Given this list of marker genes Calm1, Spata6, Spata33, Slc22a14, Rho, Daam1, Cfap69, Dnah5, Hydin, Pkd2 (polycystin 2, transient receptor potential cation channel), Timd2, Slc26a6, Oaz3, Timd5, Dnai4, Acta2, Qrich2 (NCBI Gene Id 217341), Ccdc42, Cd24a, Omp, Crocc, Mlf1, Il4i1, Catsper2, Camsap3, Cimap1b, Ccdc65, Tmem262, Dnah17, Saxo4, Aldoart1, Cfap107, Klc3, Pierce2, Dnajb13, Tekt2, Bbof1, Marcks, Spaca5, Ift81, Ttll8, Tuba1a, Cimip4, Cfap90, Rap1a, Oxct2b, Dnah1, Cfap73, Dnai1, Spag4, Tsga10, Dydc1, Cabcoco1, Prkaca, Ace, Pkd1, Brwd1, Lyzl6, Cfap36, Scnn1a, Odf1, Catsperg2, Atp1a1, Iqca1, Lrrc46, Atp1a4, Slco6c1, Dnah7c, Mroh2b, Efcab6, Ssxb10, Sord, Catsperd, Septin4, Cfap210, Cfap70, Flacc1, Dnah7a, Kif9, Gli2, Fhad1, Ran, Drc7, Cimip2c, Cimip2b, Ssxb16, Pacrg, Akap4, Rnf38, Ift27, Slirp, Pmfbp1, Irgc, Efhc1, Saxo1, Dnah8, Pde1a, Spmip4, Tubb4b, Rsph6a, Tpgs1, Tacr1, Dnah7b, Nme5, Bbs2, Hif1a, Tssk1, Spag16, Cul3, Cfap276, Ssxb5, Rsph4a, Cimip2a, Ssxb3, Cfap43, Tssk6, Efcab9, Kcnu1, Gapdhs, Mns1, Dnai2, Pgk2, Dnah9, Rsph1, Ropn1, Atp1b3, Wbp2nl, Ccdc34, Cabs1, Fscb, Bbs1, Septin10, Ak2, Catspere1, Gstm5, Ccdc172, Atg16l1, Catsper3, Ssxb15, Drc3, Garin2, Dnhd1, Odf4, Ak7, Nherf1, Aldoa, Pierce1, Dnaaf11, Ribc2, Ropn1l, Cfap206, Tacr2, Anxa1, Dnah14 (NCBI Gene Id 381311), Ssxb14, Ift88, Slc9c1, Ssxb8, Ssxb13, Saxo2, Fsip1, Dync2h1, Ccdc181, Morn5, Spaca9, Ift20, Catsperz, Hspd1, Efhb, Cfap221, Havcr1, Spag17, Atp1b1, Cfap300 (NCBI Gene Id 234912), Cst11, Ift74, Spata19, Ribc1, Cfap95, Ccdc40, Rsph9, Ttll3, Rsph3b, Arl13a, Spa17, Nek5, Slc26a3, Adcy10, Spef1, Ak1, Ccdc38, Cfap100, Tomm20, Gabarap, Cep20, Odad4, Cfap53, Cfap58, Tssk4, Ofd1, Spef2, Tbc1d21, Ttll1, Vdac2, Cimap1a, Tcp11x2, Cfap68, Dnah12, Ldhc, Rpgr, Cfap74, Dusp3, Efcab2, Zmynd12, Slc9b1, Tas2r120, Cfap52, Ssna1, Cfap57, Tmem232, Atp2b4, Actl7a, Nphp1, Abhd2, Septin12, Tekt1, Adgb, Dynlt4, Cfap119, Septin2, Septin7, Fsip2, Cep89, Cfap65, Stard10, Wdr19, Spmip5, Dld, Dnah6, Iqub, Ct55, Iqcd, Ccdc103, Cfap20, Nme8, Tekt4, Tektl1, Spag8, Dnah10, Cfap91, Pcnt, Akap3, Defb1, Rabl2, Spag6l, Cfap141, Dnali1, Tcp11, Ctsh, Fbxl13, Intu, Spmip10, Spmip8, Adam15, Spaca3, Spata3, Ssxb6, Pramel1, Catspere2, Tppp2, Ssxa1, Cfap126, Tektip1, Ift46, Spata18, Ddx6, Daw1 (NCBI Gene Id 75839), Cfap44, Timd6, Tmem249 (transmembrane protein 249), Dusp21, Clxn, Sqstm1 (NCBI Gene Id 18412), Tekt5 (tektin 5), Ptchd3, Ift172, Defb37, Ldha, Hsp90aa1, Kif2a, Spmip6, Slc9b2, Pgam1, Mkks, Pafah1b1, Rsph14, Cfap47, Eno4, Catsper1, Dnah3, Odf2, Ttll9, Pcdh11x, Pfkm, Tekt3, Cabyr, Ssxb1, Cfap144, Catsperb, Rsph3a (radial spoke 3A homolog (Chlamydomonas)), Lyzl4 (NCBI Gene Id 69032), Drd2, Gk2, Catsperg1, Lrrc23, Dnah2, Usp26, Ttc29, Akap9, Ppp3r2, Dnaaf5, Ppp3cc, Hyal3, Arl13b, Grk3, Odad3, Spag6, Cetn2, Nme7, Dnah11, Wdr54, Cd52, Tssk3, Ccdc39 (NCBI Gene Id 99728), Drc1, Txndc2, Bbs4, Akap14, Vps13a, Cfap45, Tacr3, Gas8, Ccr6, Septin6, Iqcg, Efhc2, Cep295nl, Dcdc2c, Slc25a31, Cfap251, Cep164 (NCBI Gene Id 214558), Ak8, Met, Tcte1, Dynlt2a1, Hvcn1, C2cd6, Cfap161, Txndc8, Mak, Spmip9, Catsper4, Ccdc153, Enkur, Cfap61, Dync2li1, Slc26a8, Kif3a, here is a description of the gene set: species: Mus musculus A cilium which may have a variable arrangement of axonemal microtubules and also contains molecular motors. It may beat with a whip-like pattern that promotes cell motility or transport of fluids and other cells across a cell surface, such as on epithelial cells that line the lumenal ducts of various tissues; or they may display a distinct twirling motion that directs fluid flow asymmetrically across the cellular surface to affect asymmetric body plan organization. Motile cilia can be found in single as well as multiple copies per cell. Mouse Gene Set: GOCC_MOTILE_CILIUM